The following is a description of a gene set: IL-7 signaling pathway species: Mus musculus Mouse Gene Set: WP_IL7_SIGNALING_PATHWAY, and this is the list of marker genes: Lyn, Pik3r1, Stat5a, Rb1, Cdk2, Irf1, Ccnd2, Gsk3b, Mapk1, Fyn, Stat5b, Stam, Map2k2, Akt1, Jak1, Sos1, Bcl2l11, Foxo1, Cblb, Stat3, Cbl, Raf1, Ptk2b, Il7r, Irs1, Irs2, Hras, Mcl1, Cltc, Bax, Foxo3, Il2rg, Map2k1, Stat1 (signal transducer and activator of transcription 1), Stam2, Shc1, Grb2, Muc1 (mucin 1, transmembrane), Ccna2, Blk, Bad, Mapk3, Jak3